Given this list of marker genes RAD51, BRCA2, RAD51C, TP53, RAD50, RAD51D, CHEK2, BRIP1, BRCA1, PALB2, BARD1, PTEN, MRE11, NBN, here is a description of the gene set: species: Homo sapiens A type of cancer that originates in the peritoneum. It is to be distinguished from metastatic cancer of the peritoneum. Peritoneal cancer can occur anywhere in the abdominal space, and affects the surface of organs contained inside the peritoneum. Human Gene Set: HP_PRIMARY_PERITONEAL_CARCINOMA Primary peritoneal carcinoma